Given this list of marker genes Itm2b, Cybb, Hpse, Alox5ap, Fau, Eef1a1, Ramp1, Lyz2, Cx3cr1, Selplg, Tmcc1, Lpl (lipoprotein lipase), Hspa1a, Limd2, Lst1, Rasgrp2, Klf2, Ccr2, Gpx1, Rras, Tmpo, Fos, Nr4a1, Pld4, Ypel3, Fosb, Lipa, Dipk1a, Plac8, Pou2f2, Btg2, Zfp36l2, Hspa1b, Klf4, Plbd1, Zyx, Hpgd, H2az1, Ctsh, Cd180, Cd52, Jund, Atf3, Glipr1, Lsp1, Gpx4, Crip1, Sat1, Myo1g, Rap1a, Camkk2, Tnfrsf1b, Coro1a, Hmgb2, Rgs2, Eef2, Hacd4, Ptpn18, Higd2a, Gngt2, Fam111a, Abi3, Rassf4 (Ras association (RalGDS/AF-6) domain family member 4), here is a description of the gene set: Cytokines mediate cell-cell communication in the immune system and represent important therapeutic targets. A myriad of studies have highlighted their central role in immune function, yet we lack a global view of the cellular responses of each immune cell type to each cytokine. To address this gap, the authors created the Immune Dictionary, a compendium of single-cell transcriptomic profiles of more than 17 immune cell types in response to each of 86 cytokines (>1,400 cytokine-cell type combinations) in mouse lymph nodes in vivo. A cytokine-centric view of the dictionary revealed that most cytokines induce highly cell-type-specific responses. For example, the inflammatory cytokine interleukin-1β induces distinct gene programmes in almost every cell type. A cell-type-centric view of the dictionary identified more than 66 cytokine-driven cellular polarization states across immune cell types, including previously uncharacterized states such as an interleukin-18-induced polyfunctional natural killer cell state. Mouse Gene Set: CUI_MONOCYTE_IL1A_RESPONSE_DN Genes negatively differentially expressed in cell type: Monocyte upon treatment with cytokine: IL-1α in mouse lymph nodes in vivo. studied in species Mus musculus from publication Cui A, Huang T, Li S, Ma A, Pérez JL, Sander C, Keskin DB, Wu CJ, Fraenkel E, Hacohen N (PMID 38057668)